The following is a description of a gene set: Any process that activates or increases the frequency, rate, or extent of dendritic cell cytokine production. Mouse Gene Set: GOBP_POSITIVE_REGULATION_OF_DENDRITIC_CELL_CYTOKINE_PRODUCTION studied in species Mus musculus, and this is the list of marker genes: Ddx1, Dhx36, Rigi, Clec7a, Nod2, Mavs (NCBI Gene Id 228607), Ddx21, Kit, Scimp, Ticam1, Plcg2